The following is a description of a gene set: Mitochondrial RNA degradation Human Gene Set: REACTOME_MITOCHONDRIAL_RNA_DEGRADATION studied in species Homo sapiens, and this is the list of marker genes: SUPV3L1, FASTK, MT-RNR1, FASTKD5, FASTKD2, SLIRP, TBRG4, PNPT1, REXO2 (RNA exonuclease 2), MT-RNR2, LRPPRC, GRSF1